The following is a description of a gene set: Abnormal upper motor neuron morphology Human Gene Set: HP_ABNORMAL_UPPER_MOTOR_NEURON_MORPHOLOGY Any structural anomaly that affects the upper motor neuron. studied in species Homo sapiens, and this is the list of marker genes: SQSTM1, VCP, TARDBP, SPG7, GBE1, TBK1, FUS, ALS2, PNPLA6, TYROBP, ALDH18A1, MATR3, CHCHD10, ERLIN2